Given this list of marker genes Cftr, Ooep, Zp2, Tcp11x2 (t-complex 11 family, X-linked 2), Vip, Plcb1, Nr5a1, Calr, Fzr1, Il1a, Crisp4, Cdc25b, Myh9, Spink13, Zfy2, Wfdc6b, Gpr149, Ube2b, Cib1, Hormad1, Ago2, Shh, Plat, Serpinf1, Nanos2, Ythdc2, Eif2s3y, Gja1, Ptafr, Clxn, Cdkn1b, Tac2, Meiosin, Smurf2, Lhfpl2, Camk2b, Shb, Oxt, Astl, Rnase9, Abcb1a, Sycp2, Insr, Vegfa, Knl1, Ddb1, Wnt4, Osm, Sema3a, Snai1, Cfap206, Syce3, Trpc2, Apela, Grb14, Usp17le, Dhx37, Ythdf2, Park7, Syde1, Npr2, Spata22 (NCBI Gene Id 380709), Esp22, Zfpm2, Adam24, Rad51ap1, Dmrt1, Nppc, Ptgdr2, Ctnnb1, Msx2, Bax, Aspm, Asmt, Wdr77, Zwint, Sulf1, Wfdc6a, Hpgds, Fam170b, Mfn2 (NCBI Gene Id 170731, mitofusin 2), Prdm14, Prdx4, Gpr3 (NCBI Gene Id 14748), Stk3, Pla2g10, Stk11, Iho1, Cntd1, Ybx3, Tcp11 (t-complex protein 11), Hdac4, Tac4, Glra1, Spink1, Bmp4, Cnr1, Irgc, Nupr1, Aurka, Pde5a, C1qbp, Wnt5a (wingless-type MMTV integration site family, member 5A), Rps6ka2, Acvr1b, Cdc20, Msx1, Tex101, Kif9, Sry, Npm2, Psma8 (NCBI Gene Id 73677, proteasome subunit alpha 8), Timp1, Tpst2, Sox9, Nlrp5, Sirt2, Wt1 (WT1 transcription factor, NCBI Gene Id 319408), Stk35, Ccr6, Ttk, Rad1, Rxra, Sfrp1, Insl6, Ovol1 (ovo like zinc finger 1), Gcm1, Fbxo5, Eaf2, Gdf9, Kit, Tac1, BC005624, Tppp2, Tacr2, Prkaca, Mettl3, Lfng, P2ry1, Cyp51, Insl3, Fbxo43, Ints13, Elf5, Hdac2, Mapk15, Retn, Mos, Ccdc87, Oxtr, Esr1, Plb1, P2ry2, Bmp7, Ednrb, Ada, Runx1, Cdc25a (NCBI Gene Id 52289), Anxa5, Eif4g3, Igf1r, Spinkl, Prdm9, Src, Dazl, Unc5c, Hoxd13, Mael, Pkdrej, Hyal3, Hvcn1, Tacr3, Il18, Bcl2l1, Cited2, Umodl1, Rnase10, Tex11, Pdik1l, Zp3, Acvr1c, Tacr1, Or4m1, Nkx3-1, Ppp2r1a, Ovgp1, Defb37, Meioc, Apc, Lif, Tmprss12, Ptger4, Piwil2, Wee2, Cfap69, Rgn, Eppin, Trip13, Stk4, Cdc25c, Igf1, Chfr, Nodal, Inhba, Ptgds, Ar, Pde3a, Arhgdib, Bnc1 (NCBI Gene Id 12173), Prss37, Dusp1 (NCBI Gene Id 98098), Iqcf1, Sod1, Pkmyt1, Rbm46, Prkacb, Stra8, Zp1, Cacna1h, Adam7, Inhbb, B4galt1, Defb1, Ankrd31, Drd4, here is a description of the gene set: Any process that modulates the frequency, rate or extent of reproductive process. species: Mus musculus Mouse Gene Set: GOBP_REGULATION_OF_REPRODUCTIVE_PROCESS